Given this list of marker genes Psmc4, Psmc3, Psmc6, Psmc1, Psmc2, Psmc5, here is a description of the gene set: species: Mus musculus Catalysis of the reaction: ATP + H2O = ADP + phosphate, which promotes unfolding of protein substrates, and channel opening of the core proteasome. Mouse Gene Set: GOMF_PROTEASOME_ACTIVATING_ACTIVITY